The following is a description of a gene set: Human Gene Set: GOBP_NEGATIVE_REGULATION_OF_CYTOSOLIC_CALCIUM_ION_CONCENTRATION studied in species Homo sapiens Any process that decreases the concentration of calcium ions in the cytosol., and this is the list of marker genes: GOT1, EPO, DRD3, ATP2B1, NOS1, SMAD3, MTNR1B, KCNK3, DRD2, KCNA5, BCL2, TMBIM6, OPRM1, SLC8A1, CALCA, ATP1A2